Given this list of marker genes KPNA3, KAT7, DLX6, CCDC6, RPRM, ITPKB, TIMM17B, ORC6, RHOH, RAB25, ABR, ASF1B, FIBP, CPNE3, SKIL, FAM107B, CKS2, RB1 (NCBI Gene Id 92728), NR1D2, ERRFI1, CLK1, APLP1, ACO2, PRC1, SGCE, S100A13, SPAST, RPA1 (replication protein A1), DNAJB1, TMEM176B, FCER1A, CXCR4, WDFY2, CLEC16A, CLIP3, GRK6 (G protein-coupled receptor kinase 6), SH2B1 (NCBI Gene Id 25970), PDCD7, MEF2C, MKRN1, N4BP1, AAK1, FAM76B, CIPC, UBE2A, MAN1A1, STXBP2, PNKP, CELF2, SNIP1, CRIPT, UBE2H, PITX1, CDCA8, UCK1, UBE2D2 (ubiquitin conjugating enzyme E2 D2), TRDMT1, C2CD3, NMT2, NEDD4L, SCAMP3, MCM7, CPSF2, CPT2, AMPD3, MDP1, RPS14, CACNB3, MPZL2, SNRNP40, CDC6, SYNJ2BP, EPAS1, SLC7A9, PLRG1, ZNF653, CMTM7, S100A1, NXT1, GNG3, GPR132, STBD1, IL1R2, PTOV1, CLCA1, PTDSS1, SYF2, GHITM, LIG1, RRM2, CHP1, CELSR1, AURKB, PLXNA2, NEO1, TBC1D10A (TBC1 domain family member 10A), TNP2, SLC25A53, RFC2, RAB4A, SELENOH, RELL1, GLRX, TRAPPC1, TLR6, MYL4, GRIN1, LGMN, SLC35D1, NF2, CCNI, F2RL1, ZBTB2, HDAC6, APLF, ACOT8, CDKL2, ZWINT, ITM2B, RBL1, SMARCD2 (NCBI Gene Id 6603), IL16, GAS2, GPLD1, TM9SF1, RNASEH2B, IFNGR2, GON4L, CENPA, SRC, REG1B, PMF1, RETREG1, ABCB1, PYGB, DPP7, ID3, ILKAP, UHRF1 (ubiquitin like with PHD and ring finger domains 1), EXO1, STMN1, ASF1A, KIF11, SIN3A, SLC27A1, PRIM2, ADK, RAP1A, CDT1, CXCL6, ENTPD2, JAK1, CD63, TMEM165, SLAIN1, STUB1 (NCBI Gene Id 10387), IL17RA, ADAM12, DXO, GLIPR2, LIMD1, DENND5A, EVI2A, TNFAIP6, FLI1, ZEB1, PDIA4, GABARAP, PCK2, NSMCE1, GPANK1, PARK7, KMT2E, TUBB, SARAF, WBP2, NCAM2, MYB, MEIS1, PRPH, ANKRD46, HMGCL, SPDL1, PRPF6, IL7R, MYL12B, ENTPD1, SFTPC (surfactant protein C), PON2, TSEN34 (NCBI Gene Id 79042), FABP5, RAP1GDS1, PLSCR1, TBR1, MCM2, STARD3, ZNHIT2, NAGK, PCMT1, PLK1, here is a description of the gene set: We wanted to test the role of mammalian E proteins E2A and HEB in the development of T cells. Using a conditional deletion system in which these proteins are deleted at the DP stage of T cell development, we compared DP thymocytes deficient for E2A, HEB or both to wild-type thymocytes Genes up-regulated in double positve thymocyte: TCF3 knockout versus TCF3 and TCF12 knockout. Human Gene Set: GSE19923_E2A_KO_VS_E2A_AND_HEB_KO_DP_THYMOCYTE_UP studied in species Homo sapiens from publication D'Cruz LM, Knell J, Fujimoto JK, Goldrath AW (PMID 20154672)